The following is a description of a gene set: Mouse Gene Set: CUI_NK_CELL_IL23_RESPONSE_UP Genes positively differentially expressed in cell type: NK cell upon treatment with cytokine: IL-23 in mouse lymph nodes in vivo. from publication Cui A, Huang T, Li S, Ma A, Pérez JL, Sander C, Keskin DB, Wu CJ, Fraenkel E, Hacohen N (PMID 38057668) Cytokines mediate cell-cell communication in the immune system and represent important therapeutic targets. A myriad of studies have highlighted their central role in immune function, yet we lack a global view of the cellular responses of each immune cell type to each cytokine. To address this gap, the authors created the Immune Dictionary, a compendium of single-cell transcriptomic profiles of more than 17 immune cell types in response to each of 86 cytokines (>1,400 cytokine-cell type combinations) in mouse lymph nodes in vivo. A cytokine-centric view of the dictionary revealed that most cytokines induce highly cell-type-specific responses. For example, the inflammatory cytokine interleukin-1β induces distinct gene programmes in almost every cell type. A cell-type-centric view of the dictionary identified more than 66 cytokine-driven cellular polarization states across immune cell types, including previously uncharacterized states such as an interleukin-18-induced polyfunctional natural killer cell state. species: Mus musculus, and this is the list of marker genes: Gstp1, Strap, Tmbim6, Pfn1, Cotl1, Vim, Tmsb10, Sipa1l3, Tubb4b